The following is a description of a gene set: Human Gene Set: GOBP_POSITIVE_REGULATION_OF_VASCULAR_ENDOTHELIAL_GROWTH_FACTOR_RECEPTOR_SIGNALING_PATHWAY Any process that activates or increases the frequency, rate or extent of vascular endothelial growth factor receptor signaling pathway activity. studied in species Homo sapiens, and this is the list of marker genes: IL1B, ARNT, FGF9, PRKCB, MIR1224, MIR296, ITGA5, VTN, GRB10, FGF10, ITGB3, MIR10A, HIF1A, VEGFB, ROBO1, PRKD2, FGF18, MT3 (metallothionein 3), MIR10B